The following is a description of a gene set: species: Homo sapiens Binding to a chemokine receptor. Human Gene Set: GOMF_CHEMOKINE_RECEPTOR_BINDING, and this is the list of marker genes: CCL14, C5 (complement C5), CCL13, NARS1, CCRL2, CCL22, CCL7, YARS1, CCL27, DEFB1, MSMP, STAT3 (NCBI Gene Id 6774), DEFB110, CX3CR1, DEFB130A, CCL24, CXCL10, CXCL16, CCL15 (NCBI Gene Id 6359), DEFB109B, CCL3, CXCL14, CXCL8, CCR2, XCL2, DEFB133, PPBP, PF4, CCL21, CCL11, CCL4L2, CCL2, CNIH4, CCL26, CXCL1, CCL1, DEFB106B, CXCL5 (NCBI Gene Id 6374), CCL19, CXCL12, CCL18, DEFB103B, CREB3, CXCL13, CKLF, CCL4, TFF2, CXCL2, CCL17 (C-C motif chemokine ligand 17), GPR15LG, DEFB103A, CXCL11, DEFB130B, CCL5, CCL8, PF4V1 (platelet factor 4 variant 1), DEFB106A, CCL28, CXCL6, ITCH (NCBI Gene Id 83737), CCL3L3, CCL23, CCL25, CXCL3, CXCL9, CCL20, XCL1, NES, DEFB4A, CCL16, STAT1, JAK1, DEFB114, S100A14, CX3CL1